Given this list of marker genes FMR1, FOXF1, REST, CBARP, LGALS9 (galectin 9), CCR2 (C-C motif chemokine receptor 2), IL13RA2, SYT4, CD84, RAP1A, STXBP3, SPI1, NCKAP1L, CD300A, RABGEF1, ADRA2A, CDK5, HLA-F (major histocompatibility complex, class I, F), GNAI2, RAP1B, NOTCH1, CEACAM1, FCGR2B, BRAF, BCR, RAP1BL, here is a description of the gene set: Any process that stops, prevents or reduces the frequency, rate or extent of regulated secretory pathway. studied in species Homo sapiens Human Gene Set: GOBP_NEGATIVE_REGULATION_OF_REGULATED_SECRETORY_PATHWAY